Given this list of marker genes TRHDE-AS1, LINC00314, DIO3, LINC00113, GRIK2, BARHL2, MIR217HG, PCSK9, PRPH, TLX3, RGS5-AS1, RNA5SP213, RPSAP43, HMCN2, LINC00992 (long intergenic non-protein coding RNA 992), LINC01830, CDH7, ASB15, GALNT15, LINC02842, RPS7P8, DRD4, INSM2, RPL21P59, MIR548XHG, SLC26A7 (NCBI Gene Id 65015), KCNA1, LINC01697, NTF3, DYTN, KLKP1 (kallikrein pseudogene 1), BMP5, GRIN2C, GRIN2A, HMGN1P14, NREP-AS1, GPC5-AS1, ST18, LINC01673, FGF5, KLK4, TRHDE, LINC02476, HS3ST3A1, MUC19, MCHR2, RNU4-70P, here is a description of the gene set: species: Homo sapiens from publication Cao J, O'Day DR, Pliner HA, Kingsley PD, Deng M, Daza RM, Zager MA, Aldinger KA, Blecher-Gonen R, Zhang F, Spielmann M, Palis J, Doherty D, Steemers FJ, Glass IA, Trapnell C, Shendure J (PMID 33184181) Human Gene Set: DESCARTES_FETAL_CEREBELLUM_GRANULE_NEURONS The gene expression program underlying the specification of human cell types is of fundamental interest. The study authors generated human cell atlases of gene expression and chromatin accessibility in fetal tissues. For gene expression, the study authors applied three-level combinatorial indexing to >110 samples representing 15 organs, ultimately profiling ~4 million single cells. The study authors leveraged the literature and other atlases to identify and annotate hundreds of cell types and subtypes, both within and across tissues. Our analyses focused on organ-specific specializations of broadly distributed cell types (such as blood, endothelial, and epithelial), sites of fetal erythropoiesis (which notably included the adrenal gland), and integration with mouse developmental atlases (such as conserved specification of blood cells). These data represent a rich resource for the exploration of in vivo human gene expression in diverse tissues and cell types. Marker genes curated from the annotated cluster as represented in the Descartes Human Gene Expression During Development database.